Given this list of marker genes Stam, Spry2, Spry1, Sh3gl3 (SH3-domain GRB2-like 3), Rps27a, Ptpn12, Shc1, Tgfa, Pag1, Arhgef7, Gab1, Hras, Cbl, Egfr, Fam83b, Grb2, Cdc42, Epn1, Btc, Csk, Ubb, Eps15l1, Areg (NCBI Gene Id 11839), Epgn, Ptpn3, Fam83a, Pxn, Ptprk, here is a description of the gene set: species: Mus musculus This event has been computationally inferred from an event that has been demonstrated in another species.<p>The inference is based on the homology mapping from PANTHER. Briefly, reactions for which all involved PhysicalEntities (in input, output and catalyst) have a mapped orthologue/paralogue (for complexes at least 75% of components must have a mapping) are inferred to the other species. part of: Signaling by Receptor Tyrosine Kinases electronically inferred by orthology from the curated human pathway Reactome Pathway: Signaling by EGFR